Given this list of marker genes EPB41L3, KLF4, LRATD1, LAPTM5, ULK2, VAMP5, CUX1, GBX2, LDB2, ENTREP3, GNPDA1, LAMTOR2, GBA2, SCN3B, CDH2, LAMA2, LMCD1, CEP19, TGFBI, RBM15, TRIM41, SCP2, HDAC5, PLCL2, KAZALD1, FUCA1, GTF2IRD1, IRAG2, EZH1, HABP4, NDFIP1, PKD1, PLEKHA6, ARL3, LRBA, CMBL, EMC9, ETHE1, COL14A1, DNAJC9, PRKAG1, ALOX5AP, TNXB, HIP1, HS3ST3A1, CD7, TEP1, GLG1, LCLAT1, AK1, GALNT3, COQ10A, COPA, PEX26 (peroxisomal biogenesis factor 26), FOXO3, HECTD3, SSBP3, CLK3, FBLN5, SSPN, CAT, ZBTB14, SBK1, BMAL1, THY1, ASPH, PLBD1, GSN, NUDT13, KIAA1217, CKB, HADH, TIMP2, CEBPZOS, BPHL, CCDC80, MYO18A, FUCA2, STAR, CYP27A1, ITGB5, NAAA, RNF130, CYB5R1, ESYT1, RP9, PAPSS1, HTATIP2, VCL, YWHAB, CD5L, MLEC (malectin), NATD1, PON3, ADGRL1, ZMAT3, MARVELD1, TRAPPC2B, DHRS7, DHRS1, PTPRB, CLASP1, CRYZ, GLIPR1, POU2AF1, CADM1, HEXB, MAN2B1, STMN1, LTA4H, ADRB1, PAK1, SUMF1, CRIP2, ABCC3, GALNT10, SIKE1, NEK3, CEP89, RASGRP2, TCF19, HOXA5, MCOLN1, LIMCH1, RXRA, CTDSP2, CTSD (NCBI Gene Id 196214), FOXJ2, CAMK1D, ITGAX, ACAT1, TSC22D1, MFAP5, TESK2 (NCBI Gene Id 96574), DUSP3, CYB5A, BMP2, PLD4, RNF181, ATP1B2, SUN1, DMD, TMEM98, EFHD1, TAFAZZIN, SYNE1, UBQLN2, ABAT, FAM13C, SARAF, POLD1, ADD1, ARHGAP9, SLC40A1, ABCA7 (ATP binding cassette subfamily A member 7), ABCA3, UEVLD, LIPA, ARRB1, ZMYND8, PILRB, IP6K1, FKBP9, FCGRT, YPEL3, PTGS1, AP2A2, PCOLCE2, CD300C, PLP2 (proteolipid protein 2), FXYD5, WBP1, COX7A2L, LCMT1, SLC25A45, NPR2, SH2D1B, BCL2L2, GDI1, VSIR, TCF21, FHL1, DGKZ, MAPK14, ACADVL, CLEC14A, GSTK1, MANBA, BMP8A, CAV1, TMEM141, CTNND2, LRRN1, ITGAE, SCAMP5, MSRB2, TLCD2, GGA2, OSBPL2, SMPD2, here is a description of the gene set: Human Gene Set: GSE9316_IL6_KO_VS_IFNG_KO_INVIVO_EXPANDED_CD4_TCELL_UP Genes up-regulated in CD4 T cells with in vivo expansion: IL6 versus IFNG. from publication Hirota K, Yoshitomi H, Hashimoto M, Maeda S, Teradaira S, Sugimoto N, Yamaguchi T, Nomura T, Ito H, Nakamura T, Sakaguchi N, Sakaguchi S (PMID 18025126) Th17 cells are enriched by sorting FR4-CD4+ T cells from SKG mice. A large number of Th17 cells also develop spontaneously when CD4+ T cells from IFN-g-deficient (IFN-g-/-) BALB/c mice are transferred to T cell-deficient RAG2-deficient (RAG2-/-) mice and subjected to homeostatic proliferation, whereas they fail to develop in similar transfer of IL-6-deficient (IL-6-/-) CD4+ T cells to IL-6-/- RAG2-/- mice. To explore the functional molecules specifically expressed by Th17 cells, we conducted Gene Microarray analysis between 10-month-old SKG FR4-CD4+ cells and age-matched BALB/c FR4-CD4+ cells, and between IFN-g-/- CD4+ cells transferred to RAG2-/- mice and IL-6-/- CD4+ T cells transferred to IL-6-/- RAG2-/- mice. The analysis revealed that 1,556 and genes were up-regulated in 10-month-old SKG FR4-CD4+ and IFN-g-/- CD4+ T cells after homeostatic proliferation, respectively, with genes shared by the two groups of genes. The genes included those encoding cytokines, chemokines, and their receptors, such as IL-1 receptor type1 (IL-1R1), IL-17, IL-22, IL-21, CCR6, and CCL20. species: Homo sapiens